The following is a description of a gene set: species: Homo sapiens part of: Regulation of CDH11 function Reactome Pathway: CDH11 homotypic and heterotypic interactions Based on surface plasmon resonance experiments, CDH11 forms a specificity subgroup with CDH8 and, probably, CDH24. CDH11 forms homotypic trans dimers, and heterotypic trans dimers with CDH8 and, based on sequence similarity, probably with CDH24., and this is the list of marker genes: CTNNB1, CTNNA1, CDH24, JUP, CDH8, CTNND1, CDH11